Given this list of marker genes Tac2 (NCBI Gene Id 21334, tachykinin 2), Tacr2, Tacr1, here is a description of the gene set: studied in species Mus musculus electronically inferred by orthology from the curated human pathway part of: Peptide ligand-binding receptors Reactome Pathway: Tachykinin receptors bind tachykinins This event has been computationally inferred from an event that has been demonstrated in another species.<p>The inference is based on the homology mapping from PANTHER. Briefly, reactions for which all involved PhysicalEntities (in input, output and catalyst) have a mapped orthologue/paralogue (for complexes at least 75% of components must have a mapping) are inferred to the other species.